Given this list of marker genes PARD6B, DDX11, DLEC1, GCH1, CEP170, SLC13A3, AKAP9 (NCBI Gene Id 10582), EDC4, MLN, CTSE, HSP90B1, AFDN, SAMM50, KCTD17, MAPRE1, GPRIN2, EFNA3, CA5BP1, TRIM37, ITPRID2, HLA-F, PTS, PTPRK, SNX4, CNTN2, NCKIPSD, EFR3A, PGK1, CSPG5, DLGAP1, ABCD3, INPP1, HS6ST1, G3BP2, POLR1F (RNA polymerase I subunit F), ACAP1, WNT2B, GNAT1, DRC3, PPP3CB, SECISBP2L, HMGA2, PRPS1L1, TGDS, HNRNPH1, CACNG3, S1PR4, TECR, NUP153, DCT, NR1H2, CNR1, ZBTB5, PTPRCAP, PBX2, NUDT3, KIF1B, PYGM, PDE1C, MDFIC, DHH, PPFIA1, SAA1 (serum amyloid A1), SRSF4, SCAND2P, MYOZ3, HTATIP2, EXOC6B, SOX15, CCNE1, IGF1R, GRPR, AMHR2, CLK3, TDG (thymine DNA glycosylase), HOMER1, CTAG2, ZBTB17, UBE2D3, PSIP1, ABCC4, APOH, CLIC2, IQSEC2, DDC, GRIK1, GNRH2, THOC2, DNPEP, GSR, DKK3, CLDN9, GADD45G, OPTN, SMNDC1, TOP1, CDKN1B, SLC30A4, ZW10, CLIC4, SACS, SNAP23, TOP3A, DEFB4A, SND1-IT1, ANGPTL7, CD27, SST, PAX9, MUC6, VAMP7, EXPH5, DCTD, HLA-J, INPP5K (NCBI Gene Id 51763), PPP1R2, PSMD7, AHR, PGRMC1, MARCKS, IRS1 (insulin receptor substrate 1), SPINK4, FBLN1, DYNC1I2, RGS1, PLPBP, TTC22, DNM2, ING2, SPAG5, ARID3A, DZIP3, MTMR6, PCDH8, BBS4, RIMBP2, ELL2, SMARCA5, RFPL3S, HSF4, MAPK1IP1L, NUP58, AP4M1, RAMP3, PRRG1 (NCBI Gene Id 5638), UGDH, ACSL1, DVL3, MEIS3P1, SSTR5, CPNE1, PSMD8, RAP2A, ARR3, UPK1B, COG2, PHF14, RNF126, EML3, CNTN6, POM121L9P, PCDHGA8, TFEC, TRAF5, MYD88, PDE1A, MBNL2, ZPR1, BCAS2, ELAVL3, TAOK2, CYB5R3, PLAGL2, MYOF, CLINT1, NQO1, HRG, PAEP, PCOLCE, ME3, STOM, GPR135, ZBTB6, CNKSR1, ZNF174, DFFA, MAPK7, ENOX2, RARRES1, CLN5, GLS, BIRC2, MRPS12, SLC12A4, SMAD1, CHGB, NTF3, here is a description of the gene set: from publication Chaussabel D, Semnani RT, McDowell MA, Sacks D, Sher A, Nutman TB (PMID 12663451) Genes down-regulated in comparison of macrophages versus macrophages exposed to L. major. studied in species Homo sapiens Monocyte-derived dendritic cells (DC) and macrophages (MΦ) generated in vitro from the same individual blood donors were exposed to five different pathogens, and gene expression profiles were assessed by microarray analysis. Responses to Mycobacterium tuberculosis and to phylogenetically distinct protozoan (Leishmania major, L. donovani, Toxoplasma gondii) and helminth (Brugia malayi) parasites were examined, each of which produces chronic infections in humans yet vary considerably in the nature of the immune responses they trigger. Human Gene Set: GSE360_CTRL_VS_L_MAJOR_MAC_DN